The following is a description of a gene set: Reactome Pathway: Glycogen synthesis studied in species Homo sapiens Glycogen, a highly branched glucose polymer, is formed and broken down in most human tissues, but is most abundant in liver and muscle, where it serves as a major stored fuel. Glycogen metabolism has been studied in most detail in muscle, although considerable experimental data are available concerning these reactions in liver as well. Glycogen metabolism in other tissues has not been studied as extensively, and is thought to resemble the muscle process. Glycogen synthesis involves five reactions. The first two, conversion of glucose 6-phosphate to glucose 1-phosphate and synthesis of UDP-glucose from glucose 1-phosphate and UTP, are shared with several other pathways. The next three reactions, the auto-catalyzed synthesis of a glucose oligomer on glycogenin, the linear extension of the glucose oligomer catalyzed by glycogen synthase, and the formation of branches catalyzed by glycogen branching enzyme, are unique to glycogen synthesis. Repetition of the last two reactions generates large, extensively branched glycogen polymers. The catalysis of glycogenin glucosylation and oligoglucose chain extension by distinct isozymes in liver and nonhepatic tissues allows them to be regulated independently. part of: Glycogen metabolism, and this is the list of marker genes: UBB, EPM2A, RPS27A, UGP2, GYG2, GBE1, PGM1, UBC, UBA52, GYG1, PPP1R3C, GYS2, GYS1, NHLRC1